Given this list of marker genes Penk, Crh, Cckbr, Mef2c, Grpr, Cck, Npas2, Ucn, Grp, Prkar1b, Gja1, here is a description of the gene set: studied in species Mus musculus Mouse Gene Set: GOBP_POSITIVE_REGULATION_OF_FEAR_RESPONSE Any process that activates or increases the frequency, rate or extent of fear response.